The following is a description of a gene set: Mouse Gene Set: REACTOME_INHIBITION_OF_REPLICATION_INITIATION_OF_DAMAGED_DNA_BY_RB1_E2F1 Inhibition of replication initiation of damaged DNA by RB1/E2F1 species: Mus musculus, and this is the list of marker genes: Prim1, Ppp2r1b, Rb1, Prim2, Ppp2ca, Pola2, Ppp2cb, Pola1, Ppp2r1a, Ppp2r3d